The following is a description of a gene set: Binding to a CCR6 chemokine receptor. species: Mus musculus Mouse Gene Set: GOMF_CCR6_CHEMOKINE_RECEPTOR_BINDING, and this is the list of marker genes: Defb3, Ccl20, Defb6, Defb40, Defb4, Defb47 (defensin beta 47), Defb14, Defb8, Defb9, Defb33, Gm6040, Defb46, Defb10, Defb1, Defb39, Defb7, Defb2, Defb11, Defb38, Defb37, Defb5, Defb48